Given this list of marker genes Psme3, Anxa2, Pkm, Tbcb, Cd300ld, Pcbp1, Mrps12, Uqcc4, Elavl1, Txnrd1, Gng5, Gorasp2, Lrrc59, Mlec, Gspt1, Csf2ra, Psmd2, Wdr83os, Myof, Vti1b, Srm, Plaur (NCBI Gene Id 18793), Clip1, Pepd, Prmt1, Mrps28, Ccl2, Lyar, Slc15a3, Dok2, Pum3, Timm17a, Ddx39a, Slc11a1, Axl, Bccip, Ppp1r14b, Atp5f1b, Mfsd5, Lilrb4b, Dlst, Cstb, Rrp15, Magoh, Morf4l2, Bud31, Gnb1, Sdc3, Tma16, Cyth4, Mapre1, Adam8, Ctsa, Tmed7, Pdgfb, Capza1, Msr1, Atp5mc3, Zfp593, Cct8, Prkcd, Itgax, Hspa9, Psap, Efhd2, Ier3ip1, Uqcrc1, Arpc5, Srpra, Fubp1, Nop16, Bcl2a1a, Ppp4c, Nop56, Mybbp1a, Pgd, Cebpb, Tuba1b, Nr1h3, Ap2m1 (NCBI Gene Id 11773), Tmed10, Ebna1bp2, Psmd11, Mcub, Ncf2, Cfl1, Polr1a, Lrp1, Glrx, Msmo1, Ywhab, Acer3, Nrp2, Ptpre, Creld2, Tomm5, Magohb, Hnrnpk, Pilra, Mif, Calr, Tcof1, Cmtm3, Mogs, Arhgdia, Chchd4, Ctsz, Hsp90b1, Fcer1g, Pacsin2, Eif5, Aprt, Mbtd1, Ctbp1, G3bp1, Lmna, Srgn, Eif1ax, Aif1, Vcp, Ewsr1, Crip1, Ell2, Lcp1, Psmb7, Myl6, Calm1, Pfn1, Acp2, Card19, Flna, Ruvbl1, Tagln2, Pitpna, Manf, Eif4a1, Eif3b, Itgam, Pdia6, Rab7b, Inf2, Cln8, Emp3, Mob4, Nsd2, Slc29a3, Colgalt1, Dusp6, Mrto4, Lpl, Tuba1c, Wdr18, Mafb, Eif4e, Lman1, Capzb, Ranbp1, Eif4g2, Tnfrsf11a, Dhcr24, Srsf2, Gtf2h1, Timm10, Ldha, Gtf3c6, Gnai3, Capza2, Ubtf, Sfxn1, Ywhaz, Hdgf, Eif5a, Vasp, Tmem120a, Capg, Unc119, Cd44, Kcnn4, Clec4n, Gapdh, Pltp, Zdhhc3, Ywhag (NCBI Gene Id 52802), Bola2, Tubb6 (NCBI Gene Id 67951), Agpat3, Tubb4b, Pgk1, Cdc34, Aen, BC005537, Mfsd1, Klf7, Cd53, Lat2, Tgfbi, Piezo1, Rbms1, Cox7a2, Ptgir, P2ry6, Rpn1, Cd36, Ehd1 (EH-domain containing 1), Psma6, Rap1a, Cotl1, Nme1, Id2, Myl12a, Reep3, Rac1, Gda (NCBI Gene Id 14544), Lgals3, Ubash3b, Entr1, here is a description of the gene set: Cytokines mediate cell-cell communication in the immune system and represent important therapeutic targets. A myriad of studies have highlighted their central role in immune function, yet we lack a global view of the cellular responses of each immune cell type to each cytokine. To address this gap, the authors created the Immune Dictionary, a compendium of single-cell transcriptomic profiles of more than 17 immune cell types in response to each of 86 cytokines (>1,400 cytokine-cell type combinations) in mouse lymph nodes in vivo. A cytokine-centric view of the dictionary revealed that most cytokines induce highly cell-type-specific responses. For example, the inflammatory cytokine interleukin-1β induces distinct gene programmes in almost every cell type. A cell-type-centric view of the dictionary identified more than 66 cytokine-driven cellular polarization states across immune cell types, including previously uncharacterized states such as an interleukin-18-induced polyfunctional natural killer cell state. Mouse Gene Set: CUI_CDC2_M_CSF_RESPONSE_UP studied in species Mus musculus from publication Cui A, Huang T, Li S, Ma A, Pérez JL, Sander C, Keskin DB, Wu CJ, Fraenkel E, Hacohen N (PMID 38057668) Genes positively differentially expressed in cell type: cDC2 (conventional dendritic cell type 2) upon treatment with cytokine: M-CSF in mouse lymph nodes in vivo.